Given this list of marker genes PIGK, GPAA1, PIGU, PGAP1 (NCBI Gene Id 80055), PIGS, PIGT, here is a description of the gene set: Human Gene Set: GOBP_ATTACHMENT_OF_GPI_ANCHOR_TO_PROTEIN studied in species Homo sapiens A transamidation reaction that results in the cleavage of the polypeptide chain and the concomitant transfer of the GPI anchor to the newly formed carboxy-terminal amino acid of the anchored protein. The cleaved C-terminal contains the C-terminal GPI signal sequence of the newly synthesized polypeptide chain.